Given this list of marker genes ALMS1, XYLT1, PDE11A (phosphodiesterase 11A), EP300, BBS9, PCNT, GJA8, CREBBP, WAC, NR3C1, PHLDB1, CEP290, PRKAR1A, NIPBL, SLC7A7, DYRK1B, BBS1, TRAPPC9, BBS12, BBS7, FMR1, TAF6, ADNP, GNAS, IFT74, USP48 (ubiquitin specific peptidase 48), GJA5 (gap junction protein alpha 5), MKKS, IGF1, AKT2, TTC8, TP53, PSMD12, XRCC4, IFT27, NPHP1, BPTF, SMC3, IGFALS, LAS1L, MEG3, SDCCAG8, BBIP1, DLK1, PCSK1, BBS4, POMC, BRAF, PHF6, IFT172, MC4R, SCLT1, RAI1, BBS10, GHR, IGF1R, MKS1, TRIM32, BBS5, SCAPER, SLC10A7, WDPCP, CFAP410 (cilia and flagella associated protein 410), USP8, HDAC8, INPP5E, RTL1, RNPC3, MAN1B1, ARL6, LZTFL1, VPS13B, BBS2, CEP19, CCDC28B, CFAP418, THOC2, BRD4, ATRX, CDH23, ZBTB20 (NCBI Gene Id 26137), SMC1A, RAD21, here is a description of the gene set: Truncal obesity species: Homo sapiens Human Gene Set: HP_TRUNCAL_OBESITY Obesity located preferentially in the trunk of the body as opposed to the extremities.